Given this list of marker genes Pcdhac2, Antxr2, Zfp426, Fmr1, Smap1, Adhfe1, Nectin1, Zfp696, Adamts10, Chst11, Dclre1b, Nkain2 (NCBI Gene Id 76197), Slc24a2, Cul4b, Srsf6, Rnase2a, Ino80d, Eml3, Fat3, Yeats2, Lhfpl6, Zfp641, Elfn1, Ikzf2, Inhbb, Ncor1, Igf2, Tgfbrap1, Rbms2, Cplx3, Ankle1, Nfatc3, Fbxo30, Osbpl9, Astn1, Mex3a, Trib2, Pcdha12, Apela, Sephs1, Npas3, Zfp14, ENSMUSG00000121861, Gcnt4, Tbrg4, Iglon5, Wdr45b, Pip4k2a, Kat2b, Enpp6, Bptf, Kcnq2, Pcdha1, Grm1, Car10 (NCBI Gene Id 72605), Clec4d, Keg1, Rrm2b, Gnb1, Rgs4, Rnf152, Hhip, Rab3ip, Onecut3, Pate9, Mmp21, Dnajc28, Pcdha8, Ttll1, Chmp1b, Tmem47, Cnga4, Rorb, Gm4847, Dtna, Triobp, Itsn2, Fam210b, Chst1, Gas2l3, Cep104, Cbx7, Slc30a7, Dsel, Npas2, Pcdhac1, Mapk6, Pcdha2, Abl2, Tead1, Pou2f2, Orai2, Gm9, Znrf3, Fam163a, Cacul1, Mtmr14, Maneal, Wnk3, Slc26a7, Metrnl, Sgk1, Srms, Lrrk1, Cacna2d2, Clip4, Grik2, Lrguk, Ankfy1, Wscd1, Elmod2, Rhebl1, Gabbr2, Nup58, Bcas3, Rspo1, Ctns, Pcdha5 (NCBI Gene Id 12941), Pcdha4, Auh, Asic2, Slc6a19, Ccdc191, Mapk10, Adamtsl3, Gls, Tmbim6, Acbd5, Efna5, Bmp7, Tnrc18, Tppp, Snap25, Bnc2, Vapb, Flrt2, Usp14, Impdh1, Pitpnb (phosphatidylinositol transfer protein, beta), Pcdha3, Ndnf, Ino80, Tet2, Nin, Adgrf2, Fblim1, Mbd5, Plxdc2, Arfgef1, Pcdha10, Kctd15, Wipf3 (WAS/WASL interacting protein family, member 3), Rnf38, Gnai3, Arpp21, Akap7, Tmem255a, Hyal1, Kpna3, Vcf1, Zdbf2, Zfp936, Adcy9, Cnga2, Ark2n, App, Pcf11, Bend3, Hbp1, Enpp1, Usp44, Camta1, Adgra1, Pcdha7, Pcdha11, Gria2, Gm4841, Luzp1, Irx4, Amotl1, Fgfrl1, Lrrc8a, Tfdp2, Slc46a3, Pcdha9, Crh, Daam1, Rars1, Pcdha6, Syncrip, Clock, Cyp1b1, Ankrd29, Lekr1, Cul5, Jcad, Tmem38b, Tnrc6b, here is a description of the gene set: species: Mus musculus Genes predicted to be targets of miRBase v22 microRNA mmu_miR_466h_5p in miRDB v6.0 with MirTarget v4 prediction scores > 80 (high confidence targets). from publication Chen Y, Wang X (PMID 31504780) Mouse Gene Set: MIR_466H_5P